The following is a description of a gene set: Any process that results in a change in state or activity of a cell or an organism (in terms of movement, secretion, enzyme production, gene expression, etc.) as a result of a transforming growth factor beta stimulus. species: Homo sapiens Human Gene Set: GOBP_RESPONSE_TO_TRANSFORMING_GROWTH_FACTOR_BETA, and this is the list of marker genes: MIR26A1, CLDN1, MIR520C, PALS1, ITGB6, TWSG1, SMAD4, SOX6, NLK, CAV3, BMP2, MIRLET7B, STUB1, BCL9, ZFP36L2 (ZFP36 ring finger protein like 2), CILP (cartilage intermediate layer protein), CITED2, XBP1, ZNF451, FUT8, SAP130, RGCC, LEMD3, APPL2, ITGB5, GCNT2, CAV2, MEF2C, ERO1A, MIR302B, MIR106A, SAP30 (NCBI Gene Id 8819), MIR18A, TGFBRAP1, USP15, MIR361 (microRNA 361), FOXH1, MIR15B, LEFTY1, MIR19A, EPB41L5, MIR130A, WNT2, HSPA5, SIN3A, SNX6, SNRNP70, WWOX, SMAD3, SKIL, FKBP1C, ID1, PML, ARID4B, MIR498, EID2, CD109, ZMIZ2, POSTN, GDF10, HSP90AB1, CAV1, PARP1, MIR21, SNW1 (NCBI Gene Id 22938), WNT5A, MIR183, SOX11, MIR20A, INTS9, PPARG, FERMT2, HSPA1A, ADAM9, CFLAR, SDCBP, FSHB, STRAP, MIR490, MIR17, WNT7A, EP300, FYN, TSKU, NDP, LTBP4, SIRT1, MIR342 (NCBI Gene Id 442909), FERMT1, YES1 (NCBI Gene Id 7525), MIR98, STAT3, XCL1, FURIN (NCBI Gene Id 5123), SMURF1, IL17F, TGFBR3L, ZFYVE9, MIR93, APAF1, LPXN, TGFBR3, FOLR1, ENG, PEG10, PDE2A, WFIKKN1, SUDS3, ING1, RBBP7, SOX5, ITGB8, NFKBIZ, SPRED1, PMEPA1, ONECUT1, MIR140, ONECUT2 (NCBI Gene Id 9480), CLDN5, ABL1, THBS1, LTBP2, RASL11B, GOT1, MIR372, MIR497, PIN1, GIPC1 (GIPC PDZ domain containing family member 1), RNF111, PRDM16, LATS2 (large tumor suppressor kinase 2), SMURF2, RBBP4, SAP30L, CRK, ITGB1, MTMR4, NODAL, TRIM33, ADAM17, KMT2A, FLCN, SNX25, SMAD1, MAP3K7, HDAC2, ITGA3, LIMS1, MIR564, SFRP1, MIRLET7G, ZFP36L1, MIRLET7F1, LDLRAD4 (low density lipoprotein receptor class A domain containing 4), OGT, PENK, GDF15, HYAL2, MIR323A, MIR19B1, NPNT, MIR424, PDCD5, FBN1 (fibrillin 1), MSTN (myostatin), FKBP1A, ZEB2, NREP, CDH5, LATS1, CREBBP, SPRED3, RUNX3, TGFB2, FNTA, TGFB1I1, FOS, MIR181A2, ASPN, PTPRK, COL3A1, BMPR1A, ARID4A, MIR30B, MIR145, SPI1, CREB1, CHST11, MIRLET7A1, MIR29B1, MIR376C, MAPK7, EMILIN1, JUN, MECOM, MIR27A, AXIN1, SKOR2, PPARA, PBLD, PDPK1, CDKN1C, DLX1, FMOD, SELENON, DNM3OS, HTRA1, TGFB1, IL4, PAK2, CRKL, GLG1, MEN1, PDE3A, HPGD, FNDC4, LRRC32, DUSP22, COL4A2, PSG9, TP53, ZEB1, BRMS1L, CDH3, MIR30A, PTK2, SMAD9, TAB1, MIR204, SLC2A10, SPRY2, SCX (scleraxis bHLH transcription factor), PIAS2, MIR212, USP9Y, FBN2, TGFBR1, TGFBR2, LTBP1, OVOL2, ZMIZ1, SMAD7, SINHCAF, AMHR2, WFIKKN2, ITGA8, ZYX, DAND5, LOX, HDAC1, SMAD5, MXRA5, BCL9L, MIR9-1, HIPK2, HTRA3, COL1A1 (collagen type I alpha 1 chain), IL17RD, BAMBI, DKK3, ACVR1, FAM89B, DAB2, ISL1, STK16, SOX9, ZNF703, SMAD2, VEPH1, USP9X, GDF5, MIR101-1, ACTA2, SMAD6, WNT1, MIR373, SPRED2 (sprouty related EVH1 domain containing 2), CIDEA, APOA1, ROCK1, GDF9, SRC, MIR142, DDR2, NKX2-1, WNT10A, BRMS1, SPRY1, MYOCD, ROCK2, TET1, LRG1, PPM1A, LTBP3, STK11, WNT4, SKI, TSC22D1, NR3C1, ACVRL1, EDN1, MIR199A1, FGFR2, PXN, ARRB2 (arrestin beta 2), ZFHX3, CDKN2B, ADISSP, ANKRD1, COL1A2, VASN, HTRA4, ING2, ZBTB7A, PDGFD, MIR27B, TGFB3, CD2AP, CITED1, NRROS, APPL1, ADAMTSL2 (NCBI Gene Id 9719)